Given this list of marker genes BBS1, UBR3, ATP6V1B1, TRPV1, TPBG, SCN11A, CHD7, ADAM11, SHANK1, ADCY3, CFAP69, CASR, OBP2B, WFS1, NTRK1, TAS2R5, PRKCG, LMX1A, GJB4, here is a description of the gene set: Human Gene Set: GOBP_CHEMOSENSORY_BEHAVIOR Behavior that is dependent upon the sensation of chemicals. species: Homo sapiens